The following is a description of a gene set: species: Homo sapiens Human Gene Set: WP_NONHOMOLOGOUS_END_JOINING Non-homologous end joining, and this is the list of marker genes: NHEJ1, XRCC4, XRCC6, PRKDC, XRCC5, POLM, DCLRE1C, POLL, LIG4, WRN